The following is a description of a gene set: Mouse Gene Set: GOBP_HEME_A_METABOLIC_PROCESS The chemical reactions and pathways involving heme a, a derivative of heme found in cytochrome aa3. studied in species Mus musculus, and this is the list of marker genes: Cox10, Ppox (NCBI Gene Id 19044), Cpox, Fech, Uros, Alad, Alas1, Urod, Cox15, Hmbs